Given this list of marker genes Cenpa, H2al1a, Smarca5, Ezh2, Uhrf2, Cbx1, Pole3, Dnmt1, Esco2, Sirt6, Baz1a, Flywch1, Baz1b, Zfp618, Ikzf1, Kdm4b, Cenpb, Cbx3, H2al2a, Kmt5c, Snai1, Kdm4d, Incenp, Kdm4a, Ncapd3, Cbx5, Cenpc1, Macroh2a1, Kdm4c, Atrx, Chrac1, Lrwd1, Hells, here is a description of the gene set: Heterochromatin that is located adjacent to the CENP-A rich centromere 'central core' and characterized by methylated H3 histone at lysine 9 (H3K9me2/H3K9me3). species: Mus musculus Mouse Gene Set: GOCC_PERICENTRIC_HETEROCHROMATIN